Given this list of marker genes Pde6g (phosphodiesterase 6G, cGMP-specific, rod, gamma), Gnb5, Ppef1, Cngb1, Fnta, Gnat1, Calm1, Gngt1, Gucy2f, Rho, Rgs9bp, Pde6b, Cnga1, Nmt1, Guca1a, Camkmt, Rcvrn, Rgs9, Sag, here is a description of the gene set: part of: Visual phototransduction electronically inferred by orthology from the curated human pathway studied in species Mus musculus This event has been computationally inferred from an event that has been demonstrated in another species.<p>The inference is based on the homology mapping from PANTHER. Briefly, reactions for which all involved PhysicalEntities (in input, output and catalyst) have a mapped orthologue/paralogue (for complexes at least 75% of components must have a mapping) are inferred to the other species. Reactome Pathway: The phototransduction cascade